Given this list of marker genes SFTPA1, MUC5B, PRDM10, PI4KA, STN1, YARS1, TERC, WNT4, PTEN, DSP, SFTPA2, AKT1, TERT, STAT3, FLCN, ARPC5, ATP11A, CCR2, PARN, FAM13A, SREBF1, ABCA3, IL6ST, RTEL1, SFTPC, DPP9, DOCK8, TTC7A, DICER1, here is a description of the gene set: studied in species Homo sapiens Human Gene Set: HP_PULMONARY_CYST A round circumscribed space within a lung that is surrounded by an epithelial or fibrous wall of variable thickness. A cyst usually has a thin and regular wall (less than 2 mm) and contains air, although some may contain fluid. Pulmonary cyst